Given this list of marker genes DLL4, USP49, FBXL9P (NCBI Gene Id 26231), THAP11, UBE2M, CHRDL1, ELOVL1, DSCAML1 (NCBI Gene Id 57453), CIB1, ZFP36L1, CLDN7, LIN28A, FBXO34, PHC2 (NCBI Gene Id 1912), ZNF281, PTPRG, SLC6A11, CTCF, CIAO1, ELP5, ZNRF2, RTL9, CMTR1 (NCBI Gene Id 23070), PKN1, FER1L6-AS1, CNKSR1, TRPC1, RCOR2, DRD2, LRP8, IL11, PAK3, SLC39A7, G3BP1, CIC, ARPC4, MAP3K11, E2F3, HNRNPDL, KLF10, ZNF335, GAS7, SOX10, HOXA3, CREB3L1, PPP2R5B, PDGFB, NFIB, RARG, FKBP14, SOX5, RIPOR1, MAP1B, HSD11B2, SIX1, RAPGEFL1, ZNF703, ASS1, FAM76A, MXD4, NFKBID, PCIF1, RARA, DDR1, CITED1, TMEM208, JOSD2, ATP5PD, LUC7L2, SCN5A, PRPH, NOTCH3, LCOR, ARID1A, ZFAND3, DGKG, NFATC3, KDM2A, MARCKSL1, NYAP1, NACC1, NR3C1, RNF220, SMAD7, C6orf89, SMG1, IL4I1, KDM3B, ZBTB7A, L1CAM, NFAT5, JADE1, WNK2, SLC25A28, IGFBP7, CERCAM, KCNH8 (potassium voltage-gated channel subfamily H member 8), PLXNC1, LOXL4, PABPC1, C2CD2L, P4HA1, ADGRL3, SP3, LMO4, HR (HR lysine demethylase and nuclear receptor corepressor), YTHDF2 (YTH N6-methyladenosine RNA binding protein F2), PPARD, MAP3K6, TTBK2, JPH1, ASTN1, TLK2, SLC12A4, PRDM16, BARX1, NUP62, TFAP4, LTA, TSPAN17, JARID2, BBS10, ATP6V1D, EIF2S1, LHX6, RXRB, MAP1LC3A, POU3F2, CSMD3, NR2C2, MLX, PTGES3, WDR53, SPACA6, HNRNPL, KITLG, TEAD2, KRT4, ETV4, TRMT1, CD83, NDST1, ARHGAP36, SLITRK5, TMSB4Y, POU3F1, TMEM131L, PTGIR, ZNF362, PLEKHA8, UBA3, CCDC24, ESAM, MKNK2, CDC14A, CBX6, CNKSR2, MED13, TSSK1B, DSCAM, UBTF, AHNAK, CTDNEP1, IGF2BP1, BAG6, ERF, MMP14, THRA, CXXC5 (NCBI Gene Id 51523), KLF13 (NCBI Gene Id 51621), TIGD6, TRERF1, FRMPD1, PPP1R12C, SOX9, MAP4, GRIK3, NSMF, PPM1E, GNL1, GRHL2, RBM15B (NCBI Gene Id 29890), KCNK12, PTMA, SEMA6C, RELB, WNT10A, HIC1, CABP7, MAP2K2, IER5L, EIF3A, JUND, RPIA, PITX2, BCL3, TSSK3, STAT3, NXPH4, DMPK, ATF5, ADRA2C, SP4, DPF3, NUFIP2, JADE2, MAFB, WNK4, MFNG, IRF1, PLP2, VEGFA, FBXL12, DGCR2, PABPC4, HIF1A, FKRP, NIBAN1, CDK9, RFX6, HOXC10, RAB5C, PRR3 (proline rich 3), LRP1, PDLIM2, SOS1, TMEM127, TKFC, EGLN2, KLF12, LDB1, UST, CENPB, KAT5, NETO1 (NCBI Gene Id 81832), S100A16, ARTN, FBRS, APLP2, APLP1, SPAG9, TMEM256, MPC2, here is a description of the gene set: Genes having at least one occurrence of the motif GCCNNNRGS in the regions spanning 4 kb centered on their transcription starting sites. This matches the TFAP2A transcription factor binding site V$AP2ALPHA_01 (v7.4 TRANSFAC). species: Homo sapiens Human Gene Set: AP2ALPHA_01